Given this list of marker genes Bub3, Fyb1, Cux1, Mindy2, Ostm1 (NCBI Gene Id 74109), Dpp9, Cmip, Exoc3, Asb8, Zfp758, Blcap, Fxyd5, Nans, Parp2, Dcaf11, Dgat1, Akr1b10, As3mt, Map1lc3b, Sidt2, Ikbip, H3c11, here is a description of the gene set: Mouse Gene Set: CUI_NK_CELL_SCF_RESPONSE_UP Genes positively differentially expressed in cell type: NK cell upon treatment with cytokine: SCF in mouse lymph nodes in vivo. from publication Cui A, Huang T, Li S, Ma A, Pérez JL, Sander C, Keskin DB, Wu CJ, Fraenkel E, Hacohen N (PMID 38057668) Cytokines mediate cell-cell communication in the immune system and represent important therapeutic targets. A myriad of studies have highlighted their central role in immune function, yet we lack a global view of the cellular responses of each immune cell type to each cytokine. To address this gap, the authors created the Immune Dictionary, a compendium of single-cell transcriptomic profiles of more than 17 immune cell types in response to each of 86 cytokines (>1,400 cytokine-cell type combinations) in mouse lymph nodes in vivo. A cytokine-centric view of the dictionary revealed that most cytokines induce highly cell-type-specific responses. For example, the inflammatory cytokine interleukin-1β induces distinct gene programmes in almost every cell type. A cell-type-centric view of the dictionary identified more than 66 cytokine-driven cellular polarization states across immune cell types, including previously uncharacterized states such as an interleukin-18-induced polyfunctional natural killer cell state. species: Mus musculus